The following is a description of a gene set: studied in species Homo sapiens Any process that results in a change in state or activity of an organism (in terms of movement, secretion, enzyme production, gene expression, etc.) as a result of a stimulus by molecules of bacterial origin such as peptides derived from bacterial flagellin. Human Gene Set: GOBP_RESPONSE_TO_MOLECULE_OF_BACTERIAL_ORIGIN, and this is the list of marker genes: NR4A1, KLRC4-KLRK1, EPHB2, NLRP7, CXCL8, HMGB1, CACTIN, SNCA, RAC1, GIT1, BDKRB1 (NCBI Gene Id 623), NUGGC, MYD88, RPL13A, SCIMP, ZFP36, IRF5, TLR4, TNIP2, PPBP, PF4, TLR2, DEFA3, LY96, TRIM41, MAPK14, TNFRSF1B, B2M, MAPK8, AXL, PELI1, CCL2, IRGM, PALM3, GFI1, HMGB2 (high mobility group box 2, NCBI Gene Id 3148), PPM1E, THBD, GPX1, PTGFR, PLSCR3 (NCBI Gene Id 57048), CASP9, PRDX3, CXCL5, IL24, LDOC1, MAP2K7, COL6A1, TBXA2R, IL10, TLR9, XBP1, TRIM5, RIPK2, CEBPE, PLCG2, CD55, AHR, PABPN1, NFKB1, CX3CR1, HADHB, ABCA1, MIR187, BCL10, CYP27B1, LTF, SBNO2, SELP, JUND, GPX4, CYP1A1, BMP6, EDN1, NLRP3, VIM, FOXP1, CYRIB, MMP8, CASP1, ABCC8 (ATP binding cassette subfamily C member 8), STAP1, MIR19A, MAPKAPK2, NOCT, MALT1, TRIM6, OTUD5, CD86, GPR31, HDAC2, IL12B, PF4V1, WNT5A, NFKBIA, HSF1, IRAK1, RPS6KA3, ACP5, DEFA1, MIR128-1, CDC73, PRKCA, PLSCR4, DEFB118, SOD2, CSF2RB, AKIRIN2, CASP8, CD6, CD36, IL1B, NOD2, LACRT, AKAP12, CD200, HMGCS2, MIR223, FGFR2, SSC5D, TICAM2, DEFA5, S100A14, NAGLU, HCK, IL36RN, PRPF8, GBP5, NFKB2, TLR5, NR1I2, CASP3 (NCBI Gene Id 836), CXCL9, NOS3, MMP3, CMPK2, PDCD4, LGALS9, IL6, TNFRSF11A, CNR2, WDR83, MAPKAPK3, IL37 (interleukin 37), PDCD1LG2, LCN2, RELA, SMAD6, IL10RA, DEFA6, CPS1, FZD5, MGST2, TAC1, VCAM1, CCR5, F2R, CD68, E2F1, IDO1, HNRNPA0, GNRH1, DEFB131A, CD24, MPO, IL18BP, S100A8, ALPL, CTR9, ARID5A, PTGER2, IRAK4, GHSR, LILRB1, ASS1, CSF3, DAB2IP, DEFB114 (defensin beta 114), NFKBIL1, SASH1, GATA1, CCL28, P2RX7, TREM2, PRDX2, AICDA, C4B, PPARD, ANKRD1, NOS2, CSF2, PTPN6, CTSG, SPI1, XIAP, MTDH, MIR342, CARD16, DUSP10, MIF, PCK2, TNF, CLDN1, ADAM9, FER, MIR21, BTK, IL18, GSTCD, CD274, CX3CL1, TIRAP, NFKBIB, IRAK3, SIRPA, NR1D1, ABL1, PRKCE, LYN, MIR140, ADAM17, PAF1, CDK4, INAVA, FBXO3 (F-box protein 3), MMP9, FGF10, CARD8, CITED1, NQO1, LCN10, TAP2 (NCBI Gene Id 92048), TNFSF4, BCR, KLRK1, MIR6869, SELE, TRAF6, SCARB1, DEFA1B, MIR766, IL23R, SLPI, UPF1, CCL27, LIAS, ERBIN, GJB6 (gap junction protein beta 6), REN, EFNB2, MEF2C, SLC7A5, PENK, ELANE, HDAC5, ZC3H12A, C2, DEFB124, ABCB1 (NCBI Gene Id 5243), TICAM1, CD180, CXCL10, PLAA, RARA, PTGIR, TNFAIP3, CD14, MIR105-1, MIR20A, LETMD1, GBP3, CXCL2, CD80 (CD80 molecule), MIR224, AKAP8, NOTCH1, UMOD, IRAK2, KMO, RHOA, CAMP, C5AR1, CASP7, TLR6, IL12A, TSPO, EDNRB, ACOD1, JAK2, MAPK3, MIR19B1, SPON2, TIFAB, LOXL1, IL36B, FOSL2, IRF3, MIR433, PTPN22, NR1H3, HPGD, ADH5, PDE4B (phosphodiesterase 4B), CDK19, LTA, SIGIRR, TNIP3, FOS, NOS1, LBP, FCGR2B, GCH1, DEFA4, KCNJ8, FMO1, NFKBIZ, TLR10, MRC1, IL36A, ATP4B, SELENOW, MIR142, SHPK, LILRA2, SLC11A1, FOXP3, ALAD, GBP2, IL13 (NCBI Gene Id 96500), CD40, PTAFR, CXCL6, IL1F10, EPO, FASLG, LITAF, SERPINE1, GSTP1, TLR1, SCGB1A1, MIR146A, IL12RB2, IRF8, CARD9, PYCARD, MAP2K3, SRR, CD96, DIO2, OPRK1, AKT1, SELENOS, IL36G, TRIB1, CCR7, IL1A, HAVCR2, CARD17P, CXCL13, MIR17, MAPK1 (mitogen-activated protein kinase 1), LILRB2, TNIP1, IFNAR1, PTPN11, BPI, S100A7, CAPN2, CHMP5, LY86, PTGER1, CEBPB, FCAR (Fc alpha receptor), NR1H4, ADAMTS13, TAB2